Given this list of marker genes CHAT, ABHD8, PIP4K2B, CAPN2, IMPA1, NR1H4, PMVK, PIK3R4, GNPAT, PCYT1A, PIGH, LPCAT3, FAR1, TTC7A, HTR2B, SERINC4, IMPA2, DGKE, ITPKC, CHKA, APOA2, PTEN (phosphatase and tensin homolog), PI4KA, PTDSS2, PPARD, DGKA, PIGN, PLCG2, PDGFA, GPAM, PIGX, SLC44A1, MTMR1, HTR2C, SACM1L, ORMDL3, FLVCR1, FIG4, OSBP, IDI1, PCYT2, INPP5E (NCBI Gene Id 56623), CDS1, PTPMT1, SMG1, LIPI, IDH1, HDHD5, ETNK2, PGAP4, MBOAT7, MTMR4, PGAP1, PIGF (phosphatidylinositol glycan anchor biosynthesis class F), PLAAT3, CHP1, BPNT2, PIP4K2A, PI4K2A, MVK, PGAP2, PTPRQ, INPP1, PIK3CA, PEMT, UVRAG, PGS1, PLSCR1 (phospholipid scramblase 1), INPPL1, FADS1, ATM, PIGS, PIP4K2C, PI4KAP2, APOA1, PLA2G4C, ABHD5, EFR3A, SGMS1, MTM1, INPP5D, FABP5, PIGP, ABHD3 (abhydrolase domain containing 3, phospholipase), LPCAT1, PIGV, EFR3B, PIK3CB, SLC44A4, PNPLA3, SH3GLB1, DOLK, SERINC1, INPP4B (NCBI Gene Id 8821), SLC44A5, IDI2, CHPT1, LCAT, IP6K2, TPTE2, AJUBA, XBP1, CRLS1, HTR2A, LPGAT1, ABCA8, PIGA, RAB38, SLC30A5, ITPKB, PIGL, DGKK, LPIN1, AGPAT4, NUS1 (NCBI Gene Id 116150, NUS1 dehydrodolichyl diphosphate synthase subunit), DPM1, PISD, PGAP3, TMEM150A, PLD1, GPAT2, PITPNM3, PIK3C3, PIGG (NCBI Gene Id 54872), INPP5F, PIGM, BMX, PIKFYVE, PDGFB (NCBI Gene Id 5155), ACSL3, ITPKA, DPM3, ATG14, TMEM38B, MTMR2, SERINC5 (NCBI Gene Id 256987), MVD, ALOX15, DGKD, CEPT1, DGKQ, SLC44A3, SPTLC2, VAC14, LIPH, SPTLC1, PIGU, OCRL, VAPA, ORMDL1, SH3YL1, MTMR6, HYCC2, LPCAT4, SAMD8, MBOAT2, SRD5A3, PLD2, ADGRF5, BECN1, LPCAT2, PIGZ, MTMR7 (NCBI Gene Id 9108), SERAC1, TTC7B, PIK3CD, AGPAT2, HYCC1, PIK3C2G, AGPAT1, DGKG, HMGCS1, PIP5K1C, CHKB, PIGW, LCLAT1, PIGQ, PTDSS1, FITM2, PIGO (NCBI Gene Id 84720), AGPAT5, PIP5K1A, CWH43, DGKZ, HMGCS2, SYNJ2, CDS2, PIK3CG, PIGB, GPAA1, PIGY, GPAT3 (NCBI Gene Id 84803), GPAT4, MPPE1, SYNJ1, ABCA2, IP6K3, DGKI, FDPS, PIK3C2B, PIK3C2A, CLN3, PIP5K1B, ISYNA1, ETNK1, TAMM41, GGPS1, PIGC, PIGT, DGKB, ACP6, MFSD2A, AGPAT3, PLA2G4A, PI4K2B, SCP2, PIGK, PIP5KL1, BPNT1, MBOAT1, PITPNM1, DOLPP1, INPP5J, SPHK2, MIR30C1, MTMR14, SLC44A2, PIPSL, DHDDS, DPM2, ABHD4, PITPNM2, PI4KB, DGKH, MTMR3, INPP4A, FABP3, SGMS2, IP6K1, SELENOI, HEXB, FITM1, INPP5K, PCYT1B, PIK3R3 (phosphoinositide-3-kinase regulatory subunit 3), PIK3R1, CDIPT, here is a description of the gene set: The chemical reactions and pathways resulting in the formation of a phospholipid, a lipid containing phosphoric acid as a mono- or diester. Human Gene Set: GOBP_PHOSPHOLIPID_BIOSYNTHETIC_PROCESS studied in species Homo sapiens